The following is a description of a gene set: species: Homo sapiens Human Gene Set: WP_PREIMPLANTATION_EMBRYO Pre-implantation embryo, and this is the list of marker genes: MACROH2A2 (NCBI Gene Id 83738), ARGFX, DDIT3, NANOGNB, TCF7L1, TFAP2B, NANOG, HMGA1, CELF3, EGR1, DNMT3L, KLF4, SMARCA4, ZFP42, ELAVL1, DLX2, FOSB, MOS, IRX5, CDX2, BATF3, ESRRA, MIR302A, TPRX1, E2F5, GATA2, LEUTX, CDH1, ZAR1, DPPA3, AQP9, SIX3, PBX1, IRF4, SOX8, SOX11, FOXD1, MXD1, PADI6, NLRP5, ZFP36, BARX2, ZFP36L2, ZSCAN4, DPRX, NR3C2, POU5F1, TEAD4, TBX3, ATP1A1, KHSRP, MTA3, MYBL1, GATA3, SOX2, NKX2-1, FOXQ1, AQP3, HNRNPAB